Given this list of marker genes IGFBP3, PPP1R15A, FRS2, PPP2R5E, CD33, ITGA1, PPP2R5A, CALM2, TIPRL, HSP90AB1, PHACTR4, PPP4R3A, SLC39A10, GTF2F1, CALM3, PPP4R3C, PPP2R5D, PPP2R5C, AMBRA1, B3GAT3, PPP2R5B, VRK3, PTPA, PLEK, GNA12, CALM1, BMP2, PPP4R3B (NCBI Gene Id 57223), VCAN, here is a description of the gene set: Human Gene Set: GOMF_PHOSPHATASE_ACTIVATOR_ACTIVITY species: Homo sapiens Binds to and increases the activity of a phosphatase.